Given this list of marker genes Clip1, Carmil1, Appl1, Ankfy1, Anxa2, Carmil2, Appl2, Mmp14, here is a description of the gene set: Mouse Gene Set: GOCC_PINOSOME A membrane-bounded, uncoated intracellular vesicle formed by the process of pinocytosis. species: Mus musculus